The following is a description of a gene set: Genes predicted to be targets of miRBase v22 microRNA mmu_miR_7073_3p in miRDB v6.0 with MirTarget v4 prediction scores > 80 (high confidence targets). Mouse Gene Set: MIR_7073_3P from publication Chen Y, Wang X (PMID 31504780) species: Mus musculus, and this is the list of marker genes: Pds5b, Zranb2, Fkbp14 (NCBI Gene Id 231997), Zbtb11, Pthlh, Mbnl1, Pla2g4b, Dek, Mrps17, Ankrd17, Snx12, Usp29, Smg1, Sltm, Fkbp10, Rhou, Hecw2, Dclk1, Ttc14, Smndc1 (NCBI Gene Id 76479), Mllt11, Toe1, Lrfn5, Cfl1, Rwdd2a, Thrb, Caap1, Rbms3, Serinc3, L2hgdh, Mef2c, Cnot6, Poc5, Strbp, Fbxo24